The following is a description of a gene set: Human Gene Set: GOBP_CRANIAL_NERVE_MORPHOGENESIS The process in which the anatomical structure of the cranial nerves are generated and organized. The cranial nerves are composed of twelve pairs of nerves that emanate from the nervous tissue of the hindbrain. These nerves are sensory, motor, or mixed in nature, and provide the motor and general sensory innervation of the head, neck and viscera. They mediate vision, hearing, olfaction and taste and carry the parasympathetic innervation of the autonomic ganglia that control visceral functions. studied in species Homo sapiens, and this is the list of marker genes: PHOX2A, CITED2, HOXA3, HOXB3, TFAP2A, NEUROG1 (NCBI Gene Id 4762), PAX2, NRP2, HOXB2, TIFAB, HOXB1, CHRNB2, PLXNA3, MAFB, SEMA3A, SIX1, HOXD3, EPHB2, PLXNA4, EGR2, PLXNA1, DCANP1, SEMA3F, TBX1, KCNA2, HOXA1 (NCBI Gene Id 3198), GLI3, ADARB1, EPHB1, ATP8B1, NRP1